Given this list of marker genes SLC43A2, SLC2A1, SLC17A7 (solute carrier family 17 member 7), SLC7A5P2, SLC7A3, LRRC8D, SLC7A2, SLC16A11, SLC66A1LP, MFSD12, ABCD2, ACE2 (angiotensin converting enzyme 2), SLC16A9, SLC25A26, ARL6IP1, TTYH3, SLC6A14, SLC38A10, SLC1A3, SLC16A1 (solute carrier family 16 member 1), SLC23A2, KCNJ10, CPT1A, CLN3, EPM2A (NCBI Gene Id 7957), CTNS, SLC27A1, SFXN2, MPC2, SLC7A9 (NCBI Gene Id 1461), SLC7A8, UCP2, ARL6IP5, SLC7A5, SLC1A1, SLC6A11, SLC46A1, SLC38A4, SLC5A6, ITGB1, SLC6A6, SLC11A1, SLC17A5 (solute carrier family 17 member 5), SLC7A13, SLC17A6, SLC16A14, SLC38A9, SLC25A15, GFAP, SLC7A6, SLC43A1, SLC38A6, SLC25A21, SLC5A12, SLC25A18, SLC3A1, ACACB, PSEN1, SLC16A6, SLC36A1, SFXN3, TSPO2, SLC7A11, SLC35D2, CLTRN, CLN8 (CLN8 transmembrane ER and ERGIC protein), SLC6A15, SLC6A20, LRRC8A, SLC25A20, SLC1A5, SLC5A8, SLC13A3, SLC22A9, SLC16A12, SFXN1, CPT1B, SLC36A4, CD36, SLC25A12, MPC1, SLC26A7, IRS2, LRP2, SLC16A8, LRRC8E, ATP1A2, TNF, SLC38A8, THBS1, SLC47A1, SLC6A7, SLC19A1, CPT2, PRAF2, ABCB1, ACSL1, TTYH2, SLC22A2, SLC66A1, AKT1, SLC23A1, SLC38A1 (solute carrier family 38 member 1), SLC7A1, ABCD4, SLC6A5, PER2, NTSR1, SLC6A13, SELENON, SLC16A7, SLC27A5, SLC38A3, ABCC5, LRRC8C, SLC25A10, SLC25A38, SLC1A2, SLC13A2, SLC36A2, SLC16A4, SLC38A11, ACSL5, GRM1, RGS2, SLC29A4, TTYH1, SEPTIN2, SLC36A3, ABCD3, MPC1L (NCBI Gene Id 347411), SLC25A11, SLC25A22, SLC7A7, SLC7A10, EMB (embigin), SLC25A13, SLC7A5P1, SLC38A2, SLC16A3, SLC1A4, SLC6A8, SLC13A5, SLC25A29, SLC25A1, ABCD1 (NCBI Gene Id 215), SLC35D1, AKT2, SLC15A4, SLC6A9, SLC25A2, ABCC1, RGS4, SLC1A6, SLC38A5, SLC17A8, LRRC8B, SLC1A7 (solute carrier family 1 member 7), SLC3A2, here is a description of the gene set: The process in which an organic acid is transported across a membrane. species: Homo sapiens Human Gene Set: GOBP_ORGANIC_ACID_TRANSMEMBRANE_TRANSPORT